The following is a description of a gene set: Human Gene Set: GOMF_NUCLEAR_EXPORT_SIGNAL_RECEPTOR_ACTIVITY Combining with a nuclear export signal (NES) on a cargo to be transported, to mediate transport of a the cargo through the nuclear pore, from the nuclear lumen to the cytoplasm. The cargo can be either a RNA or a protein. species: Homo sapiens, and this is the list of marker genes: XPO1, CSE1L, XPO4, RAN, XPO5, CALR, XPO6, XPO7, NUP214, EIF4ENIF1, RANBP17, NUP42